The following is a description of a gene set: species: Mus musculus Mouse Gene Set: REACTOME_ACTIVATED_TAK1_MEDIATES_P38_MAPK_ACTIVATION activated TAK1 mediates p38 MAPK activation, and this is the list of marker genes: Ubb, Ikbkg (inhibitor of kappaB kinase gamma), Nod1, Ube2n, Mapkapk3, Uba52, Mapk14, Traf6, Ripk2, Irak1, Ubc, Mapkapk2, Map3k7, Tab1, Tab2, Map2k6, Tab3, Mapk11, Nod2, Irak2, Uba52rt, Ube2v1, Rps27a, Map2k3